The following is a description of a gene set: species: Homo sapiens Human Gene Set: GOMF_NITRITE_REDUCTASE_ACTIVITY Catalysis of the reaction: nitrite + acceptor = product(s) of nitrate reduction + reduced acceptor., and this is the list of marker genes: MTARC2, NGB, CYB5R3, CYB5B, CYGB, MB, CBS, ENSG00000274276, MTARC1